Given this list of marker genes Lpin2, Rbm26, Agtpbp1, Lrrc1, Sirt7, Litaf, Irx2 (NCBI Gene Id 16372), Adamts8, Amfr, Onecut1, Sh3rf3, Vps9d1, Camkk2, Gins1, Shc3, Cep70, 1700086P04Rik, Inafm2, Rnf7l, Synm (NCBI Gene Id 73939), Gnai2, Foxl2os, 5330438D12Rik, Eif2ak3, Zhx2, Vps54, Atrn, Akap1, Gpr27, Pcyox1l, Ppp1r26 (protein phosphatase 1, regulatory subunit 26), Map4k4, Bbof1, Rpl10a, Trp53inp1, Aig1, Snrk, Srsf6, Atg16l2, Zbtb39, Fam168b, Sh3d19, Anapc13, Dhrs13, Lhfpl2, Mapk6, Tspan4, Lgr6, Gm27017 (NCBI Gene Id 102631857), Ankhd1, Ankrd54, Syt9, Mapkapk5, Dhrs1, Klhl35, Caskin1, Arf3, Bmf, AI661453, Atp8a2, Tmem68 (transmembrane protein 68), Gclc, Plpp1, Arhgef40, Usp36, Brd2 (NCBI Gene Id 547337), Pkig, Tprg1l, Kctd1, Tab2, F630040K05Rik, Dmxl1, Rnf227, Carm1, Aak1, Podxl2, Gfpt1, 2810025M15Rik, Dagla, Ube2ql1, Hpf1, Rnf214, Dock9, Chn2, Jkamp, Mapk14, Nxf1, Nrm, Icmt, Pank2, Ikbkb, Ccser1, Me1, Osbpl6, Kat2a, Zcchc14, Ano4, Pde3b, 4931440P22Rik, Ankrd46, Lingo2, Nadk, Zswim7, Elac1, Auts2, Pxylp1, Nemp2, Tpk1, Gm15927, Galnt2, B4galnt3 (beta-1,4-N-acetyl-galactosaminyl transferase 3), Atp6v0b, 2500004C02Rik, Cpa3, 2210408I21Rik, Tafa5, Ccne2, Ttc39b, Ap5z1, Arhgap21, Wipf3, Uck2, Gm10069, Sbno2, Plekha5, Guf1, Pex7, Noc2l, Plch2, Cnppd1, Mast2, Smagp, 4921531C22Rik, Fip1l1, Spopl, Map4, Svbp (NCBI Gene Id 69216), Sgcb, Atf5, Dnajc6, Chd1l, Snph, Dnajc21, Ift80, Get4 (NCBI Gene Id 67604), Psip1, Naa20, Smarcc2, Kdelr2, Map2k7, Dnajb14, Dnajc1, Tor2a, Zmiz1, Far1, Has2os, 1700027A07Rik, Pls1, Myo6, Tns3, Tchp, Zmiz2, Pmpca, Plekhf2, Ptges2, Tbc1d2b, Tspan33, Gadd45g, Fbxl2, Ankrd39, Sh3pxd2b, Sorl1, Nrf1, B230112G18Rik, Pon2, Dzip3, Bcar3, Meaf6, C130021I20Rik, F2r, Pbx4, Vezt, Smad5, Tmem132a, Gng5, Jmjd1c, Slc15a4, Naxd, Adgrb2, Gm15672, Tm7sf3, Phf2os1, Sun1, Myrf, Dipk1a, Gm14966, Slc25a28, Gpr156, Kansl1, Nfatc1, Rpl29, Rps15a, Gm16892, Sanbr (SANT and BTB domain regulator of CSR), Gm22863, Zfp213, 3110083C13Rik (NCBI Gene Id 73208), Plekhb2, Glrb, Bend6, Entrep2 (endosomal transmembrane epsin interactor 2, NCBI Gene Id 70638), Clybl, Baiap2, Rabl6, Gm12963, Fam13b, Man1a2, Ei24, Celf6, Slc25a30, Bax, Tbk1, Cirbp, Hs2st1, Klf7, Dtnbp1, Zfp652os, Junos, Basp1, Zfp612, Bmpr1a, Tc2n, Mars2, Egln2, Aldh16a1, Adal, Fgd6, Rbm6, 9530036O11Rik, Ovol1, Tox3, Odad4, Rsrp1, Ndufc1, Frmpd1, 1700010B13Rik, Rab35, Izumo4, Tatdn3, Maneal, Ankrd29, Brdt, Vrk2, Cdh24, Zfp326, Fars2, Hectd2, Lmln, Tmem64, Nub1, Rcn1, Nsf, Rmnd1, Atg13, Rb1, Lsm2, Sf1, Sympk, Retreg2, Ube2f (NCBI Gene Id 98459), Selenof, Smox, Ttc14, Phf3, L3hypdh, Sncaip, Slc12a2, Etohd2, Hp1bp3, Rnf111, Phf2, E2f1, Tex261, Usp10, Wnt7b, A930001C03Rik, Gpr137c, Plxnb1, Pcnx2, Htr7, Snx7, Arhgef4, Txndc9, Cdc42bpa, H13, Mnd1, Clstn1, Lag3, BC001981, Rab15, Atp5f1a, 4930519P11Rik, Riox2, Nrg3, Atf1, Fhip2a, Tradd, Slc27a4 (NCBI Gene Id 99453, solute carrier family 27 (fatty acid transporter), member 4), Anapc11, Slc25a51, Shank1, Tal1, Large1, Ptpmt1, Elk4, Adgrl1, Bend3, Dyrk2, Atp6v1a (ATPase, H+ transporting, lysosomal V1 subunit A), Chmp4b, Tnnt1 (troponin T1, skeletal, slow), Armt1, Zdhhc21, Acot7, Sult4a1, Glrx3, Kif16b, Gm15850, Usf2, Grhl1, Zfp523, Grik5, Plcg1, Tulp4, Evpl, Lacc1, Gm15283, Gm16599, Arhgap39, Thrb, Polr2m, 1700104B16Rik, Mbd5, Gm6275, Sfxn1, Aldh9a1, Zscan25, Harbi1, Sclt1, Ccnyl1, Gm2449, Nudt17, Parp12, Pex5l, Peg3, Grik4, Mxd4, Glrx2, Hic2, Nsun3, Commd7, Gm10745, Mpzl1 (NCBI Gene Id 68481), Kpna1, Il6ra, Dnajc11, Spats2, Jag2, Eprs1, Sart3, Zmynd19, Usp29, Krt23, Zfp385b, Tmbim4, Lrba, Smurf1, Smad1, Herc2, Zbtb7a, Cacnb1, Lyrm4, Tox2, Ubiad1, Pip5k1b, Sdf4, Pip4k2a, Fkbp8, Ran, Hdhd2, Tmem134, Rasef, Usp40, Gnb1, Sez6l, Srsf5, Ranbp17, Zfp41, Ankrd40, Anpep, Gm13726, Mogs, Agbl3, Otud1, Nr2c2, Ube2j1, Ghr, Npr3, Filip1l, Atg10, Bicdl1, Mfsd6, Sco1, Plcb4, Nos1ap, Ctnna3 (NCBI Gene Id 73853), Vps26a, Sash1 (NCBI Gene Id 70097), Slc39a3, Ndrg1, Kxd1, Gm14204, Gm13241, Tanc2, Cul1, Foxp1, Mcur1, Macroh2a1, Mcm3ap (minichromosome maintenance complex component 3 associated protein), Znfx1, 1600023N17Rik, Pole, Inca1, Rnf38, E130114P18Rik, Gm11240, Srebf1, Tex12, Derl1, Ppp2r5a, Pfkfb3, Pam, Rrn3, Raf1, Fyttd1, Fbln1, Rabif, Pphln1, Klf15 (NCBI Gene Id 66277), Gm17709, Vash1, C030034I22Rik, Nat9, Wdr12, Tanc1, Fbxl3, Gm16062, Ephx4, Zfp703, Kmt5a, Susd4, 2810013P06Rik, Sgsm1, Lysmd2, Mpdz, Src, Shld2, Psen1, Col16a1, Mob1a, Rplp0, Uggt2, Rasal2, Dcaf8, Ntn1, Slc35g2, Pdk3, Ramp1, Peds1, Cebpb, Parm1, Chmp5, Pi4kb, Arl8a (NCBI Gene Id 68724), Cep63, Mir6936, Lrrc4 (leucine rich repeat containing 4), Atg9b, Ehd2, Epc2, Bambi-ps1, Ccdc122, Bok, Arl4c, Zc3h14, 2700049A03Rik, Tbc1d7, Cnot6l, Hnrnpd, Nlrx1, Slc35a3 (solute carrier family 35 (UDP-N-acetylglucosamine (UDP-GlcNAc) transporter), member 3, NCBI Gene Id 70398), Cdon, Rab4b, Rara, Zfp276, Tmem165, Znrf2, Aagab, Mtss1, Fkbp9, Fbxo42, Gm4890, Ttc28, Eif5b, Frg2f1, Hmgn2, Gm15569, 4930515G01Rik, 1700065D16Rik, Fstl3, Arfgef2, A730020E08Rik, Clint1, Gls2, Pfdn2, Eif1ad, Gpbp1, Ptpra, Gm15222, Terf2, Dipk1c, Irak3, Ankrd34b, Itgb4, Stk19, Trmt10c, Lzts2, Ywhab, Atp9a (NCBI Gene Id 11981), Dnmt3a, Irx3os, Dync2i2, Atp2c1, Ralgds, Pomp, Zc3h3 (NCBI Gene Id 245129), Drosha, Abcc1, Akap10, Napa, Gata2, Orc4, Gm527, Nit1, Aurkb, Nlk, Upf1, Lrp3, Limd2, Gpt2, Cpne7, Slc22a23, Zbtb18, Fbxo33, 1700123M08Rik, Qrfprl, Eif4ebp2, Atp8b1, Zkscan8, Rnf123, Kcmf1, 9130019P16Rik, Frrs1l, Zfp362, Sema6a, Cenps, Lyar, Akap7 (A kinase anchor protein 7), Glrx5, Gpr180, Rnf157, Man2a2, Pprc1 (NCBI Gene Id 226169), Ahcyl1, Gm6659, Avl9, 1700108N11Rik, Med7, Tmem62, Arap2, Ube2d1, Spata1, Nfxl1, Myrip, Orc3, Slc44a2 (NCBI Gene Id 68682), Apba1, Tmem151a, Cpeb2, Fkbp1b, Dst, Tmed2, Ktn1, Trpm7, Tigd2 (NCBI Gene Id 68140), Ndfip2, Gm9767, Ttc9b, Mrps35, Ankrd13d, Ddx55, Atp11a, AI480526, 1110059E24Rik (RIKEN cDNA 1110059E24 gene), Dda1, Spred1, Shisa7, Gm10517, Atl1, Ap5b1, Cbfa2t2, Fkbp4, Gne, Crls1, Gm11423, Minpp1, Naa50, Satb1, Elmod2, Cnpy3 (canopy FGF signaling regulator 3), Gm12101, Slc35e3, Serf1, Gskip, Gcat, Ube2e3, Actn3, Ociad1, Tsen15, Sgip1, Cadm4, Zfp628, Slc37a1, Eefsec (NCBI Gene Id 65967), Enah, Gm25794, Pgp, Kat6a, Gm6623, Aip, 4933433G15Rik, Vwa2, Thbs4, Ggt7, Grip1, Rab10os, Patl2, Pias2, Tmem104, Zmym6, Kcnq5, Dgat1, Gm8010, Mtres1, Gm26901, Cdc42bpb, Gm15564, Tecpr1, Nop9, Ltbr, Mrps7, Samd5, Adprm, Rad9b, 4930429F24Rik, Celf5, Dyrk1a, Hdgf, Asnsd1, Ism2, Dab2ip, 1600014C23Rik, Abhd5 (abhydrolase domain containing 5), Sema6d, Cdkn2a, 1810021B22Rik, Rnf139, 2510039O18Rik, Bri3bp, Fbxo21, Dna2, Ube2e1, Foxj3, Dnal4, Dhx16, Hint2, 1500002C15Rik, Siva1, Gm16136, Dtwd1, Tmem266, Vegfb, Mir203, Gm15784, Abcc10, Adamts20, Osgin2 (NCBI Gene Id 209212), Paip2b, Igfbp2, Sult2b1, Nrip1, Pitpna, Gga3, Rab3il1, Safb2, Slc7a6, Senp6, Gm4219, Setd6, Gm9260 (NCBI Gene Id 668595), Abhd12, Rtn4rl2, Rad23b (RAD23 homolog B, nucleotide excision repair protein), Ldlrad3, Slk (STE20-like kinase), Lysmd3, Lhx2, Gm13146, Thoc7, Hmces, Clcc1, Pxmp2, L3mbtl3, Mmaa, Cep120, 9230116N13Rik, Gm10840, Tcf4, Mix23, Ptk2, Rap1gap, Paip1, Nkx3-1, Mcph1, Pibf1, Epb41l3, Tmed9, Pip, Rnf10, Ppib, A530072M11Rik, Napepld, Pgap4, Gm6277, Ctdsp1, Kif2a, Dcp2 (NCBI Gene Id 70640), Taf10, Fhdc1, Ppp4r2, Ddx20, Pllp, Ubqln1, Dlk1, Ppm1e, Ptprb, Cdkl3, Brca2, Cox5a, Nrp2, Trim44, Casp9 (NCBI Gene Id 12371), Srrm1, Npepl1, Tln1, Rnf20, Nol4l, Bnc1, Gm24381, Gm7417, Eaf2, Tbl1xr1, Ldb1, Sgms1, Slc7a10, Galnt1, Klhl25 (kelch-like 25), 1110006O24Rik, Wnk2, Sgms1os1, Fhip1b, Clptm1, Dmrtb1, Ndst3, Cacna1c, Nf1, Entr1, Fxr2, Med30, Il1r1, Smarcd3, Rnf114, Prom2, Nipsnap2, 4930440C22Rik, Eef2k, Unc80, Hnrnpu, Mob2, Rspo1, Abr, Eif5a, Gm5067 (predicted gene 5067), Nsl1 (NSL1, MIS12 kinetochore complex component), Kif1c, Hdac7, Pacsin2 (NCBI Gene Id 23970), Adarb1, Agrp, Rbms1, Lrrc8d, Zcrb1, Nr2f6, Ptpn23, Tmem117, Crtc3, Notch1, Actr3b, Cad, Ccdc6, Gcn1, Zfhx3, Cacnb4, Ralbp1, Cul3, Grk2, Aebp2, Itgav, Trnp1, Sesn1, Bfsp1, Seh1l, Asic1, Barhl1, Nfatc2 (nuclear factor of activated T cells, cytoplasmic, calcineurin dependent 2, NCBI Gene Id 99036), Snhg6, A730017L22Rik, 5031439G07Rik, Dnaja1, Ugcg, Pcbp3, Cav2, Kctd6, Iqch (NCBI Gene Id 78250), Slc25a11, Fbxo9, Mrps2, Itgb3bp, Plekhm2, 2810408I11Rik, Dvl1, Gtf2e2, B4galt7, Foxa3, Clstn2, Chrdl2, Ctnnbip1, Tmem168, Sdk1, Prpsap1, Ranbp9, Hddc2, Ppp2r3d, Gm13238, Zfp513, Gaa, Dnajc8, Gm5914, Nop14, Emilin2, Galk1, Spata13, Gm19569, Hacd1, Hmgxb3, Ctbp1, Fhl3 (four and a half LIM domains 3), Csgalnact2, Rhou, Sulf2, Pdk1, Dhx37, Comt, Nudt3, Plcb3, Adam12, Naa16, Ttn, Enpp4, Gm29642, Rbm4b, Elavl2, Igsf21 (NCBI Gene Id 230868), Rcbtb1, Fgf9, Sh3pxd2a, Cox8c, 2610306M01Rik (RIKEN cDNA 2610306M01 gene), Gm40190, Usp53, Fndc4, Cdcp1, Gm13375, Wnt4, Gm7993, Acss2, Cdc20b, 4933431K23Rik, Ddost, Banf1 (NCBI Gene Id 98145), Anapc16, Klhl36, Ppp2r2b, 4930532G15Rik, Camsap1, Alyref, Aimp1 (aminoacyl tRNA synthetase complex-interacting multifunctional protein 1), Phactr2, Pcbd2, C130060C02Rik, Tmem121, Mdga1 (MAM domain containing glycosylphosphatidylinositol anchor 1), Thsd4, Cfap20, Ice1, Dmxl2, Parp8, Ap2a2, Abcg2, Ciz1, Wbp4, Nmrk1, Pdia6, Gm13034, Adgrb1, A930029G22Rik, Lcmt2, Pygo1, Sorcs2, Rapgef1, Sema3c, Katnbl1, Bltp3a, Grk4, Arhgap35, Ankrd13a, Gcgr, Cul5, Nfasc, Banp, Sppl3, Sbk1, Cpne2, Septin8, Tbck, Gm10501, 4933406I18Rik, Gm8495, Ndufaf6 (NCBI Gene Id 76947), Mmp14, Ostf1, Cilk1, Mir207, Haglr, Setd2, Slc9a2, Zfyve9, Pde10a, Snx29, Lef1, Zyg11a, Epha8, Atp1b1, Gm20716, Foxl2, Tex30, Yaf2, Map2k2, Rnf19b, Syt10, Tmem87b, Tspan5, Gm11560, Nav2, Vopp1, Elac2, Cldn12, Gm6345, Raph1, Gm7291, Prkar1b, Yars2, Cntnap1, Bola3, Rbm39, Zbtb24, Mtmr7 (myotubularin related protein 7), Hdgfl3, Pxk, Dennd2c, H6pd, Nrsn1, Cip2a, Ahdc1, Rgl1, Sik3, Egr1, Camkv, Klhdc2, Trap1, Notch3, Rraga, Cacfd1, Gm38158, Adnp, Rufy3, Acer2, Fam162a, Leprot, 4933437G19Rik, Ddx4, Rab23, Erbin, Fam210b (family with sequence similarity 210, member B), Alpk3, Zdhhc17, Sdc3, U2af1, Lgals3, Get1 (NCBI Gene Id 93958), Nrg4, Morc2a, Gm10138 (predicted gene 10138), Gpr12, Gm15634, 3110070M22Rik, Gm11767, Rest (NCBI Gene Id 72127), Gli3, Cln6, A730060N03Rik, Zfp341, Syncrip, Rasgef1c, Zfp777, Pld6, Hmgcr, Zfas1, Acadsb, Akip1, Glud1, Ehmt1, Zfta, Arl5a, Hdlbp, Sepsecs, Gm5468, Itm2b, Plxdc1, Ing5, Gm6556, D3Ertd751e, Gm26513, Ccnd3, Slc37a3, Msl1, Srsf3, Crlf2, Hes1, Fam118a, Pik3ca, Ccdc38, Gdpd3, Meis3, Pms1, 6030458C11Rik, Pdcd6ip, Peli1, Golm1, Nkain1, Esrrg, B230217O12Rik (NCBI Gene Id 320879), Guk1, Gm25878, Nr4a2, Safb, Ppp4r1, Bag1, Dgkz, Arhgap44, Clpx, Parl (NCBI Gene Id 52663), Mob3a, Akt1, Paxip1, Ube2r2, Mcu, Galnt11 (polypeptide N-acetylgalactosaminyltransferase 11), Gm20760, Ak4, Rcor1, A930032L01Rik, Ttc32 (tetratricopeptide repeat domain 32), Trim3, Gm3336 (NCBI Gene Id 637091), Dnajc5, Macir, Chsy3, Rusc2, Eif4a3l1, Rab40b, Ggact, Eif5, Alkbh7, Rhod, Eif2ak1, Tsfm, Mapk13, Acbd3, Cwh43 (cell wall biogenesis 43 C-terminal homolog), Txnrd2, Pou4f1, C130036L24Rik, Mpv17l, Golga1, Rnf126, Bag2, Rnf215, Tnk2, Acads (acyl-Coenzyme A dehydrogenase, short chain), Sfr1, Rab12, Twsg1, Top6bl, Slc35e2, Plekhh3, Jak2, Iscu, H2az2, Ascc1, Chmp6, Proser2, Sh3gl3, Rars2, Tsn, Skil, Rcan2, Rpl11, Card19, Cant1, Pigq, Txndc16, Baiap3, Nsmce3, Rab22a, A730056A06Rik, Syndig1l, Fgf22, BC004004, Epo, Ttc19, Pcsk7, Fbxo10, Eif4e2, Gm26627, 4930426L09Rik, Rcc1, Tug1, Mfsd4a, Rad18, Fbxl8, Msantd3, Ssh2, Ttc4, Gclm, Eepd1, Arfgef1, Fam227b, Kbtbd2, Gm11789, Pigz, Gm9484, Cpeb3, Capzb (NCBI Gene Id 80668), Rora, Cgas, Bsg, Lmx1b, 1700007L15Rik, Flcn, Gm26684 (NCBI Gene Id 102638507), Tmem243, Nr2f2, Khdrbs3, A430018G15Rik, Zfp382, Stam2, Zswim4, Ccdc43, Usp4, Usp48 (ubiquitin specific peptidase 48), Adgrl2, Ccdc62, Rubcn, Poglut3, Lrig1, Map7, BC034090, B230208B08Rik (RIKEN cDNA B230208B08 gene), Cux1, Zfp572, Mir7236, 4930599N23Rik, Ppp2r5b, Nr5a1os, Adamtsl5, Gprin1, Abhd16a, Ets1, Med28, Homer3, Kcp, Atxn7l3b, Gm14320, Gramd1a, Pitpnm2, Vac14, Gnb2, Mapt, Gpbp1l1, Nmd3, Ythdf1, Smad3, Gatm, Gm26520, Wasf2, Rerg, Cacna1d, Senp2 (NCBI Gene Id 75826), Snx25, Rtraf, Limk2, Smn1, Tmem240, Iba57, Trerf1, Fgf18, 3110082J24Rik, Dpm1, Sh3gl1, Tmem54, Hexa, Rap1gapos, Acsl4, Epb41l4b, Hsd17b8, Rnf103, Runx2, Zdhhc24, Gm29707, Asah1, Ptov1, Kcnma1, Ago2, Gfra4, Rab11fip2, Marchf8, Mrps15, Smim10l2a, Nup35, L3mbtl4, Phf21a, Tbc1d4 (NCBI Gene Id 545073, TBC1 domain family, member 4), Nfat5, Gm5841 (predicted gene 5841), Bcl11a, Prkar2a, Rnf167 (NCBI Gene Id 74807), Gm16580 (NCBI Gene Id 100417756), Zfp219, Pcdh19, Dnajc13 (DnaJ heat shock protein family (Hsp40) member C13), Dxo, Baz2a, Suv39h2, Bcar1, Cyrib, Eif4e3, Cbx4, Dleu2, Pde4dip, Mfsd5, Gm8641, Lats2, Mks1, Nr5a1, P4hb, Ubqln2, Creb3, Senp1, Ndrg3 (N-myc downstream regulated gene 3), Hdac4, Zfp609, Cnn2, Glis1, Mbd6, Rock2, Farp2, Tmem201, Gm12327, Akain1, Ncs1, Zfp422, Mir7075, 3110031N09Rik, Tsen2, Ppp4r1l-ps (protein phosphatase 4, regulatory subunit 1-like, pseudogene), Taf4, Crbn, Arl15, Fosl2, Adamtsl3, Rnf220, Slc30a9, Fgf11, Pih1d1, Gna12, Fam124a, Trabd, C1qbp, Synj2, Fsd1l, Cyth2, Pim1, Washc4, Mir449c, Afdn, Lemd2, Slc6a21, 1700125G02Rik, Gemin7, Bod1l, Luc7l, Pex11b, Gm8503, Pwwp3b, Entpd5, Fam50a, Elf1, Stx17, Zfand1 (NCBI Gene Id 99875), Gm2453, Dazl, Adam17, Tstd2, Sec63 (SEC63 homolog, protein translocation regulator), Tmem267, Ywhah, Lmo4, Dnaaf9, Ubl3, Klhl2, Prickle1, Pdp1, Gm16208, Zfp236, Kcnk9, Polr2l, Bbx, Rapgef4, Mir375, Arrdc3, Isca1, Lifr, Susd6, Usp33, Clip1, Pwwp2a, Tgs1, Rsrc1, Dhx33, Derl3, Apc, Adamts18, Csnk1g2, Ptprd, Mpnd, Rfxap, Ppm1g, Gm12428, Slc45a4, here is a description of the gene set: studied in species Mus musculus Genes containing one or more binding sites for (Grhl3) in their promoter regions (TSS -1000,+100 bp) as identified by GTRD version 20.06 ChIP-seq harmonization. Mouse Gene Set: GRHL3_TARGET_GENES from publication Yevshin I, Sharipov R, Kolmykov S, Kondrakhin Y, Kolpakov F (PMID 30445619)